Given this list of marker genes C8A, HLA-DRB1, PGM3, IFNGR1, NDE1, STAT1, BCL6, JAK3, WIPF1, UNC13D, C4A, CYBB, TNFRSF13C, NCKAP1L, NCF1 (NCBI Gene Id 653844), SLC39A7, TMEM70, SH2D1A, PRTN3, IL12A-AS1, CR2, IRAK4, MVK, IL7, CCR1, IL12A, NCF2, BCL10, FOXP3, CARMIL2, IRF4, PIK3R1, ERAP1, BCL2, L2HGDH, HLA-DPB1, ICOS, STXBP2, TRAF3, SNORA31, RAG2, KLRC4, PTPN22, CYBA, DBR1, DNASE1L3, MRTFA, ARPC1B, SLC6A19, ENG (endoglin), SLC35C1, CD19, C8B, SPI1, CFI, NLRP3, NLRC4, CARD11, TICAM1, CYBC1, CD79A, CIITA, CD27, IGLL1, HLA-DPA1, WAS, BTK, MEFV, P4HA2, MNX1, TNFRSF13B, VANGL1, BLNK, UBAC2, IGHM, CD40LG, IL2RG, TLR4, CARD9, DOCK8, FCGR3B, LBR, STX11, LRRC8A, ACVRL1, IL23R, FGFR3, HYOU1, NCF4, CLTRN, CD28, C1QC, C4B, STK4, CD79B, TLR3, UNC93B1, IL10, RAG1, XIAP, IKBKG, FAS, HLA-B, MYD88, CXCR4, TFRC, PRF1, STAT4, CFB, FOXN1, CTLA4, TCF3, IRF3 (NCBI Gene Id 3661), ATRX, TBK1, here is a description of the gene set: Unusual infection by anatomical site Human Gene Set: HP_UNUSUAL_INFECTION_BY_ANATOMICAL_SITE An unusual infection classified by the affected body part. studied in species Homo sapiens